Given this list of marker genes Taf7, Il33, Nlrc5, Hsph1, Ciita, Nlrp12, here is a description of the gene set: Mouse Gene Set: GOBP_MHC_CLASS_I_BIOSYNTHETIC_PROCESS species: Mus musculus The chemical reactions and pathways resulting in the formation of major histocompatibility protein class I.